The following is a description of a gene set: Mouse Gene Set: REACTOME_AMINO_ACID_TRANSPORT_ACROSS_THE_PLASMA_MEMBRANE studied in species Mus musculus Amino acid transport across the plasma membrane, and this is the list of marker genes: Slc38a2, Slc6a15, Slc7a9, Slc6a20a, Slc38a4, Slc6a14, Slc7a3, Slc43a1, Slc7a5, Slc6a6, Slc36a2, Slc7a1, Slc43a2, Slc3a1, Slc36a4, Slc3a2, Slc7a7, Slc6a19, Slc6a18 (NCBI Gene Id 22598), Slc16a10, Slc36a1, Slc7a6, Slc7a10, Slc7a11, Slc1a5, Slc38a3 (solute carrier family 38, member 3), Slc7a8, Slc1a4, Slc38a5, Slc38a1, Slc25a29, Slc6a12